The following is a description of a gene set: Genes containing one or more binding sites for (ZNF23) in their promoter regions (TSS -1000,+100 bp) as identified by GTRD version 20.06 ChIP-seq harmonization. Human Gene Set: ZNF23_TARGET_GENES studied in species Homo sapiens from publication Yevshin I, Sharipov R, Kolmykov S, Kondrakhin Y, Kolpakov F (PMID 30445619), and this is the list of marker genes: STUM, PNPLA6 (patatin like phospholipase domain containing 6), ENSG00000221040, ASS1, MIR4518, SYT5, GINS3, STAT6 (signal transducer and activator of transcription 6), GAS8, DNM2, RFX1, CUEDC1, ITGAL, LIG1, RAB37, CEACAM19, RPH3AL